The following is a description of a gene set: species: Mus musculus This event has been computationally inferred from an event that has been demonstrated in another species.<p>The inference is based on the homology mapping from PANTHER. Briefly, reactions for which all involved PhysicalEntities (in input, output and catalyst) have a mapped orthologue/paralogue (for complexes at least 75% of components must have a mapping) are inferred to the other species. part of: TP53 Regulates Transcription of Cell Death Genes Reactome Pathway: TP53 regulates transcription of several additional cell death genes whose specific roles in p53-dependent apoptosis remain uncertain electronically inferred by orthology from the curated human pathway, and this is the list of marker genes: Rabggta, Rabggtb